Given this list of marker genes NDUFAF7, GOT1 (NCBI Gene Id 2805), NDUFV2, PNKD, MPC1L (NCBI Gene Id 347411), NDUFAF4, MT-CYB, ATP5MJ, MT-CO2, COQ10A (coenzyme Q10A), UBC, NDUFA6, ATP5PB, SUCLG1, PDP2, NDUFB10 (NCBI Gene Id 4716), NDUFA12, TIMM21, LYRM7, COX11, NDUFA1, SLC25A22, HCCS, HIGD2A, COX19, SFXN4 (sideroflexin 4), SDHA, ATP5F1A, MAEA, PDHX, PET117, PKM, D2HGDH, MPC1, TMEM177, ECSIT, COX17, UCP1, TMEM223 (transmembrane protein 223), NDUFS3, MT-CO1, ATP5MC1, NDUFB7, ATP5MG, MT-ATP8, NDUFAF8, WDR26, GSTZ1, COX7A2, MKLN1, RANBP9, UCP3, COX7A2L, ATP5MC3, SDHAF4, ATP5F1C, FH, FAHD1, FOXRED1, NDUFV3, NDUFS2, NDUFB8, PDP1, DMAC2L, CS, ISCA1, HIGD1A, TACO1, GPT, SUCLG2, NDUFA2, GID4, LDHAL6A, SDHAF1, SLC25A27, ATP5PF, UQCRC1, MT-CO3, HIGD1C, NDUFB3, SLC25A13, SIRT4, NDUFA8, COX6B2, COX6A2, MDH1, PDK1, ATP5F1D, IDH3B, COX6A1, COA5, GID8, HAGH, NFS1, NDUFB11, PDK4, COX8A, NDUFA10, SCO2, SLC25A4, NDUFB6, NDUFAF2 (NCBI Gene Id 91942), IDH3G, RMND5B, ETFB, NDUFS4, NDUFS8, ATP5PD, SUCLA2, SDHB (NCBI Gene Id 96200), COX5B, NDUFA9, SIRT3, COX18, UQCC6, SDHAF3, ACO2, CYCS, LETM1, PDHB, COX4I1, SDHAF2, MPC2, NDUFB4, ACAT1, TIMMDC1, SLC25A18, COX7A1, NDUFV1, COX7B, IDH3A, RAB5IF, HSCB, DMAC2, MT-ND2, NDUFS6, COA1, TRAP1, KGD4, LDHB, ACAD9, NDUFB9, ISCU, PC, NDUFB2, SCO1, MT-ND3, UQCRB, PYURF, COA3, UCP2, ATP5PO, IDH2, PDPR, ATP5MC2 (ATP synthase membrane subunit c locus 2), L2HGDH, UBA52, ISCA2, COX7C, PKLR, COX20, NDUFB1, HSPA9, GOT2, NDUFB5, RMND5A, ME3, NDUFAF3, NDUFS7, UQCC1, ATP5MF, VDAC1, UQCRFS1, ATP5F1E, OGDH, UQCRC2, SLC25A11, NDUFS1, LDHAL6B, MDH2 (NCBI Gene Id 4191), CYC1, SMIM20, UQCRHL, NDUFA3, NDUFC1, NDUFS5, SDHC, DLST, MT-ATP6, NDUFAF5, PET100, COXFA4, MT-ND6, UQCRQ, NEK1, NNT, PDK3, DLD, PGAM5, COX16, UQCR11, ETFDH, LYRM4, ME1, TTC19, NDUFAF1, NDUFA7, TMEM126B, ATP5ME, NDUFA13, UQCR10, COX6C, COX4I2, DLAT, UQCC2, SURF1, NUBPL, LYRM2 (LYR motif containing 2), MT-ND5, DMAC1, COQ10B, FXN, SLC25A12 (solute carrier family 25 member 12), SLC25A14, COX14, UQCC5, COX6B1, ETFA, ATP5MK, ARMC8, PDK2, UQCC3, UBB, BCS1L, COX8C, OXA1L (NCBI Gene Id 5018), LDHA, NDUFA5, RPS27A, TMEM126A, NDUFC2, CMC1, PDHA2, GLO1, NDUFAB1, MT-ND1, NDUFAF6, COX5A, TMEM186, NDUFA11, PDHA1, LDHC, ADHFE1, UQCRH, SDHD, ME2, COX15, PM20D1, CSKMT, MT-ND4, ATP5F1B, here is a description of the gene set: Pyruvate metabolism and the citric acid (TCA) cycle together link the processes of energy metabolism in a human cell with one another and with key biosynthetic reactions. Pyruvate, derived from the reversible oxidation of lactate or transamination of alanine, can be converted to acetyl CoA. Other sources of acetyl CoA include breakdown of free fatty acids and ketone bodies in the fasting state. Acetyl CoA can enter the citric acid cycle, a major source of reducing equivalents. These reducing equivalents are re-oxidized back to NAD+ in the electron transport chain (ETC), coupling this process with the export of protons across the inner mitochondrial membrane. The chemiosmotic gradient created is used to drive ATP synthesis.<p>In addition to its role in energy generation, the citric acid cycle is a source of carbon skeletons for amino acid metabolism and other biosynthetic processes. One such process included here is the interconversion of 2-hydroxyglutarate, probably derived from porphyrin and amino acid metabolism, and 2-oxoglutarate (alpha-ketoglutarate), a citric acid cycle intermediate. Reactome Pathway: Aerobic respiration and respiratory electron transport species: Homo sapiens part of: Metabolism